The following is a description of a gene set: Any process in which a chromosome is transported to, or maintained in, a specific location. species: Mus musculus Mouse Gene Set: GOBP_CHROMOSOME_LOCALIZATION, and this is the list of marker genes: Chmp5, Cdk1 (cyclin dependent kinase 1), Trappc12 (NCBI Gene Id 353082), Sirt1, Sgo1, Snhg15, Kifc1, Ankrd53, Chmp4c, Ube2b, Ndel1, Dctn2, Nuf2, Tex14, Champ1, Chmp3, Majin, Fam83d, Rad21l, Becn1 (NCBI Gene Id 56208), Kif22, Kat5, Cenpe, Sun1, Zwint, Lmna, Cenpf, Kif18a, Mapre1, Chmp1b, Nup62, Ttl, Racgap1, Chmp1b2, Pibf1, Cdc42, Kif14, Numa1, Spc25, Gem, Ccdc66, Mlh1, Nde1 (NCBI Gene Id 67203), Eml3, Rcc2, Zfp207, Actr2, Iffo1, Meioc, Abraxas1, Ccnb1-ps, Map1s, Cdca8, Bub3, Nup98, Seh1l, Ccnb1, Atm, Cdt1, Cul3, Aurkb, Terb1, Vps4b, Arhgap33os, Abraxas2, Rrs1, Ska2, Katnb1, Ska3 (spindle and kinetochore associated complex subunit 3), Ect2, Kif2b (kinesin family member 2B), Spdya, Spo11, Kifc5b, Cdca5, Kif2c, Cdc23, Cenpq, Vps4a (NCBI Gene Id 78220), Cep63, Eml4, Ska1 (spindle and kinetochore associated complex subunit 1), Knstrn, Terb2, Spag5, Dsn1, Chmp2b, Knl1, Actr3, Chmp7, Sirt2, Mei1, Birc5, Spice1, Nudc, Chmp1a (NCBI Gene Id 72909), Psrc1, Spdl1, Kat2b, Hnrnpu, Rab11a, Ttk, Kpnb1, Mis12, Nek2, Dync1h1, Terf1, Pinx1, Chmp6, Cenpc1, Mad1l1, Zw10, Septin1, Rb1, Ndc80, Pmf1, Apc, Fmn2, Spc24, Chmp4b, Brca2, Incenp, Kash5 (NCBI Gene Id 384619), Nsl1, Chmp2a